The following is a description of a gene set: studied in species Mus musculus Any process that activates or increases the frequency, rate or extent of activity of the transcription factor CREB. Mouse Gene Set: GOBP_POSITIVE_REGULATION_OF_CREB_TRANSCRIPTION_FACTOR_ACTIVITY, and this is the list of marker genes: Epha5, Crtc1, Adgrf1, Reln, Lpar5, Crtc2, Crtc3 (NCBI Gene Id 70461), Tssk4, Camk1d, Adcy8, Crebbp, Cd200, Adcy1